The following is a description of a gene set: Any structural anomaly of the bronchi, i.e., of the airways leading from the trachea to the lungs. studied in species Homo sapiens Human Gene Set: HP_ABNORMAL_BRONCHUS_MORPHOLOGY Abnormal bronchus morphology, and this is the list of marker genes: NEK10, DNAH5, SLC26A9, NCKAP1L, ATP11A, UNC119, RPGR, STK36, IGLL1, FBLN5, DNAAF3 (NCBI Gene Id 56162), IL2RG, TET2, POLE, IL6ST, DSP, ICOSLG, SERPINA1, TAP2 (NCBI Gene Id 92048), DNAH11, CEACAM3, RAC2, TNFRSF13C, ABCA3, DNAAF11, CD8A, FNIP1, SLC41A1, DIAPH1, SFTPA2 (NCBI Gene Id 83342), IL21R (NCBI Gene Id 50615), MYRF, ODAD1, SCUBE3, STN1, SLC39A7, DNAAF2, WDR1, DNAAF6, MGP, IRF8, SPI1, CLCA4, CD79B, DNAI2 (dynein axonemal intermediate chain 2), CCDC65, POLD3, DOCK8, BLNK, FGFR1, RSPH4A, MCIDAS, BTNL2 (butyrophilin like 2), SLC11A1, KCNN4, FCGR2A, CCNO, MALT1, RFX7, ODAD4, LTBP4, HRAS (NCBI Gene Id 338029), TAFAZZIN, GSTM3, SLC6A14, CARD11 (caspase recruitment domain family member 11), CD81, AGR2, IL10RB, GAS2L2, LAT, FGFR2 (NCBI Gene Id 2263), STX3, PTEN, GCLC, LRBA, ORC6, ARL2BP, MS4A1, SLF2, TNFSF12, KRT5, RIPK1, TNFRSF13B, FOXJ1, IRF9, MPEG1, HYDIN, MUC5B, CTLA4, POLR1A, IRF2BP2, POR, DNAAF1, CCDC39, CFTR, C1QB, SLC34A2 (solute carrier family 34 member 2), HLA-DRB1, NDUFA6, DRC1, BTK, RSPH1, LRRC8A, CCDC103 (coiled-coil domain containing 103), ATM, TERT, FAM13A, TAP1, OFD1, BLM, EGFR, POLD1, DDRGK1, TCF3, FCHO1, PGM3, CEACAM6, SYK, IFT56, MIF, CR2, HFE, BRWD1, IGKC, TTC12, LRRC56, SCNN1G, PARN, CARMIL2, DNAH9, MYH11, SCNN1A (NCBI Gene Id 6337), NFKB1, NBN (nibrin), DNAAF5, B2M, FLNB, NME8, TPP2, CXCR4, STAT1, ORC4, CFAP74, IGHG2, RIN2, EMILIN1, PAK2, DNAAF4, RSPH3, ERF, RNU4-2, RTEL1, DNAH1, USP26, SPEF2, NFKB2, TNFRSF9, SASH3 (SAM and SH3 domain containing 3), CD19, EHMT1, ODAD2, TGFB1, CFAP221, SLC9A3, ICOS, RFX5, ZNF699, ELN, ODAD3, ARHGEF1, DNAL1, DNAI1, SPAG1, RSPH9, PI4KA, CD79A (CD79a molecule), SEC61A1, NME5, BACH2, DNMT3B, DPP9, CARD10, DNAJB13, ZMYND10, SFTPC, SFTPA1, STX1A, DCTN4, RASGRP1, IDS, RAC1, POLA1, ARSL, IL17RA, TERC, SMARCA2 (SWI/SNF related, matrix associated, actin dependent regulator of chromatin, subfamily a, member 2), STK4, KAT6A, SLC29A3, SOX9, SLC26A2, GAS8, TP73, GMNN, EDNRA, MAGT1, PIK3R1, CFAP298, PIK3CD, SCNN1B, GNPTAB, IGHM, KRT14, STAT3, DOCK11, ZNF341, HMOX1, ALDH18A1 (aldehyde dehydrogenase 18 family member A1), CFAP300, CCDC40